The following is a description of a gene set: species: Mus musculus The process in which an epithelial cord, rod or tube bifurcates at its end. Mouse Gene Set: GOBP_DICHOTOMOUS_SUBDIVISION_OF_AN_EPITHELIAL_TERMINAL_UNIT, and this is the list of marker genes: Ctsh (NCBI Gene Id 13036), Sema3a, Nrp1, Areg, Plxna1, Plxnd1, Vangl2, Sema3c, Foxd1 (forkhead box D1), Tfap2c, Celsr1